The following is a description of a gene set: studied in species Mus musculus from publication Zheng Y, Josefowicz SZ, Kas A, Chu TT, Gavin MA, Rudensky AY (PMID 17237761) Human Gene Set: ZHENG_FOXP3_TARGETS_IN_T_LYMPHOCYTE_UP Genes with promoters bound by FOXP3 and which are up-regulated only in mature (peripheral blood) regulatory CD4+ T lymphocytes. Transcription factor Foxp3 (forkhead box P3), restricted in its expression to a specialized regulatory CD4+ T-cell subset (T(R)) with a dedicated suppressor function, controls T(R) lineage development. In humans and mice, Foxp3 deficiency results in a paucity of T(R) cells and a fatal breach in immunological tolerance, causing highly aggressive multi-organ autoimmune pathology. Here, through genome-wide analysis combining chromatin immunoprecipitation with mouse genome tiling array profiling, we identify Foxp3 binding regions for approximately genes and for an intergenically encoded microRNA. We find that a large number of Foxp3-bound genes are up- or downregulated in Foxp3+ T cells, suggesting that Foxp3 acts as both a transcriptional activator and repressor. Foxp3-mediated regulation unique to the thymus affects, among others, genes encoding nuclear factors that control gene expression and chromatin remodelling. In contrast, Foxp3 target genes shared by the thymic and peripheral T(R) cells encode primarily plasma membrane proteins, as well as cell signalling proteins. Together, our studies suggest that distinct transcriptional sub-programmes implemented by Foxp3 establish T(R) lineage during differentiation and its proliferative and functional competence in the periphery., and this is the list of marker genes: CENPK, GPLD1, STARD6, ZNF608, GATA3, CPM, CC2D2A, VRK2 (NCBI Gene Id 7444), RRAS2, SAMSN1, SGIP1, IFT57